Given this list of marker genes ST8SIA2, SLC35D3, DNAJC15, PRKD1, DLX6, SLC39A8, TES, SLC16A14, WDR59, RLN2, GREM2, RASA4B (NCBI Gene Id 100271927), CCDC3, LEPR, HOTAIR, MIAT, HMCN1, FAT3, GRM7, ADM, ST6GALNAC5, YPEL3, GABPB1-AS1, PDK4, TMEM200B, NTRK3, PLEKHA6, IGFBP5, ST6GAL2, GATA3-AS1, PCDH18, AASS, TSPYL5, PAK5, ARK2C, PRICKLE1, NR2F2, TGIF1, HRK, LIX1, CD200, BCL11A, JDP2, FOXO3, CBX3, BGN, GFRA2, LRRN1, FBXL7, CENPBD1P, FTX, ADCY1, HDAC9, LHX9, GATA3, CHST7, WNT5A, NECAB2, MFAP2, CUX1, NREP, PDPR, BDNF, XIST, ST8SIA1, SATB1, ARHGAP28, GUCY1A2, UCMA, SLITRK6, LINC03072, CP, LDLRAD4, BOC, SLC16A9, C7, TMEM44, CD24, SCGN, ADAMTS5, WWOX, LATS2, EFNA2, FRMD4A, ROBO2, ZNF395, SSTR2, PDGFRA, MMP16, FBLN1, HAUS5, ADGRL3, CAMK1D, FN1, ZNF423, FAM124A, SNAP91, MYRF, TNRC18, PCDHB2, COL3A1, AK5, FGF14-AS2, AMPH, FSTL1, DCHS1, C2orf68, LONP2, NR2F1, SERPINF1 (NCBI Gene Id 5176), UBE2E2, EDNRB, PHACTR3, GABPB1-IT1, TMEM204, ADAMTS1, MATN2, ALKAL2, here is a description of the gene set: Human Gene Set: HOELZEL_NF1_TARGETS_DN Retinoic acid (RA) induces differentiation of neuroblastoma cells in vitro and is used with variable success to treat aggressive forms of this disease. This variability in clinical response to RA is enigmatic, as no mutations in components of the RA signaling cascade have been found. Using a large-scale RNAi genetic screen, we identify crosstalk between the tumor suppressor NF1 and retinoic acid-induced differentiation in neuroblastoma. Loss of NF1 activates RAS-MEK signaling, which in turn represses ZNF423, a critical transcriptional coactivator of the retinoic acid receptors. Neuroblastomas with low levels of both NF1 and ZNF423 have extremely poor outcome. We find NF1 mutations in neuroblastoma cell lines and in primary tumors. Inhibition of MEK signaling downstream of NF1 restores responsiveness to RA, suggesting a therapeutic strategy to overcome RA resistance in NF1-deficient neuroblastomas. Genes down-regulated in SH-SY5Y cells (neuroblastoma) after knockdown of NF1 by RNAi. from publication Hölzel M, Huang S, Koster J, Ora I, Lakeman A, Caron H, Nijkamp W, Xie J, Callens T, Asgharzadeh S, Seeger RC, Messiaen L, Versteeg R, Bernards R (PMID 20655465) studied in species Homo sapiens